The following is a description of a gene set: species: Mus musculus from publication Chen Y, Wang X (PMID 31504780) Mouse Gene Set: MIR_8107 Genes predicted to be targets of miRBase v22 microRNA mmu_miR_8107 in miRDB v6.0 with MirTarget v4 prediction scores > 80 (high confidence targets)., and this is the list of marker genes: Papola, Myef2, Ankrd40, Tpx2, Ercc6, Irak1bp1, Nelfcd, Cpne1 (NCBI Gene Id 69777), Dpp8, Hcrtr2, Fbxo38, Oxa1l, Zfp704, Chic1, Krt26, Slc4a7, Nr5a1, Omg, Ppip5k2, Tcf12, Eif1b, Hkdc1, Rtp2, Trim40, Slc35f3, Nfam1, Drd1, Cd3d, Ppp2r5e, Arhgap12, Atp2b4, Nexmif, Cdk14, Pakap, Kras, Pclo, Dapl1, Map1b, Col5a2, Maco1, Ppargc1b, Pcnp (PEST proteolytic signal containing nuclear protein), Pitpnc1, Dcaf5, Btbd7, Smg6, Noct, Atp10a, Krt6b, Inhbc, Rnf128, Pogk, G3bp2, Hpgds, Mfsd1, Gpr88, Rtf1, Dnajc10, Ap1g1, Clns1a, Kdm5a, Ifit2 (interferon-induced protein with tetratricopeptide repeats 2), Hlf, Wsb1, Magee1, Clint1, Pigm, Slc2a10, Stxbp5l, Mylip (NCBI Gene Id 353050), Arid4a, Hoxa10, Aak1, Zfp169, Tns3, Wdr48, Arpc5, Zrsr2, Vcf1, Syt14, Deup1, Paip2b, Zic1, Mtcl2 (microtubule crosslinking factor 2), Cox15, Ccr9, Dcaf10, Pde6c, Snx1, Tle1, Cdc14a (NCBI Gene Id 229776), Tbl1x, Htr4, D7Ertd443e, Slf2, Prkab1, Scai, Pnma2, Styk1, S1pr1, Cmtr1, Lpcat2, Nol4 (nucleolar protein 4), Lrch3, Arhgap35, Rcan2, Sostdc1, Psmd5, Usp3, P2ry14, Tanc2, Rbm22, Chrna10, Mt4, Shroom2, Col9a3, Glud1, Vcf2, Htr2c, Laptm4a, Hus1, 4931414P19Rik, Dnaaf2, Ube3a